Given this list of marker genes PUS10, PUS3, RPUSD4, PUSL1, PUS1, PUS7, here is a description of the gene set: Human Gene Set: GOBP_TRNA_PSEUDOURIDINE_SYNTHESIS species: Homo sapiens The intramolecular conversion of uridine to pseudouridine in a tRNA molecule.